Given this list of marker genes SLC44A4, SLC44A5, SLC44A2 (solute carrier family 44 member 2 (CTL2 blood group)), SLC10A6, SLC44A3, SLC44A1 (solute carrier family 44 member 1), SLC5A7, here is a description of the gene set: Reactome Pathway: SLC-mediated bile acid transport part of: SLC-mediated transport of organic anions species: Homo sapiens This pathway serves as collection of reactions categorized as SLC-mediated bile acid transport